Given this list of marker genes TRAF7, AKT1, SMARCE1, SUFU, PDGFB, PIK3CA, TERT, NF2, SMARCB1, SMO, BAP1 (NCBI Gene Id 8314), here is a description of the gene set: species: Homo sapiens Human Gene Set: HP_INTRACRANIAL_MENINGIOMA Intracranial meningioma